Given this list of marker genes CLCN1, GNE (glucosamine (UDP-N-acetyl)-2-epimerase/N-acetylmannosamine kinase), HSPG2, MTMR14, DNM2, SGCG, ATP2A1, LRP12, SCN4A, here is a description of the gene set: Human Gene Set: HP_EMG_MYOTONIC_DISCHARGES High frequency discharges in electromyography (EMG) that vary in amplitude and frequency, waxing and waning continuously with firing frequencies ranging from 150/second down to 20/second and producing a sound that has been referred to as a dive bomber sound. EMG: myotonic discharges species: Homo sapiens